Given this list of marker genes CCL19, ANXA1, RIPK2, CD80, HLX, SOCS5, here is a description of the gene set: Any process that activates or increases the frequency, rate or extent of T-helper 1 cell differentiation. studied in species Homo sapiens Human Gene Set: GOBP_POSITIVE_REGULATION_OF_T_HELPER_1_CELL_DIFFERENTIATION